The following is a description of a gene set: from publication Yevshin I, Sharipov R, Kolmykov S, Kondrakhin Y, Kolpakov F (PMID 30445619) species: Mus musculus Genes containing one or more binding sites for (Twist1) in their promoter regions (TSS -1000,+100 bp) as identified by GTRD version 20.06 ChIP-seq harmonization. Mouse Gene Set: TWIST1_TARGET_GENES, and this is the list of marker genes: Mir144, Trim37, Map2k1, Tirap, Spi1, Nudt22 (nudix hydrolase 22), Tubg2, Mecom, Sh2d6, Cep131, St6galnac2, Chd1l, Duxf1, Mir5615-2, Spata31e2, Ctsa, Bag2, mt-Ta, Hmgxb3, Prpf4, mt-Tl2, Gm20788, 4930426I24Rik, Bricd5, mt-Tn, Mir6991, mt-Nd1, Slc11a1, Vsig10l, mt-Th, Car5a, E130018O15Rik, Neurl2, Rpp40, Tmem267, Ldlrap1, mt-Te, Fa2h, Ppp1r15b, mt-Ts2, Gm26122, Gem, 9930012K11Rik, Slc22a15, Dlgap5, Mlxipl, Gm16087, mt-Tp, Bicdl1, Gm3716, Cfb, A530053M12Rik, Icam2, Loxhd1, Mus81, Mtnr1a, Kalrn, Hspa2, Il12a, Zfp667, Dscc1, Gm5989, Stk11ip, Slc24a4 (NCBI Gene Id 353057), 1600014C10Rik, Gm15564, Lclat1, Zfp382, Pxylp1, Gm25805, Podxl2, Etv6, Mir6236, Sp2 (Sp2 transcription factor), Sit1 (NCBI Gene Id 54390), Mir6934, mt-Ty, Foxred1, Prdm11, Fbrsl1, Ovca2, Kmt2d, Dync1li1, Srpra, Ncaph, Cfl1, mt-Nd6, Hmx1, Mical1, mt-Rnr2, Utp18, D7Ertd443e, Gm454, Chst13, Tprn, Cd164, Psmd9, Abhd12, 3110070M22Rik, Tnk1, Atp6v0e, Mir1936, mt-Tc (mitochondrially encoded tRNA cysteine), Gm15912, Mir3059 (NCBI Gene Id 100526516), Tppp, mt-Nd5, Tnrc6c, Fyn, Map3k5, 4930555F03Rik, Ubr4, Pum1, Lrrc61, Gm23517, Mex3a, Sfi1, mt-Tv, mt-Tl1, Tmc6, Lamb3, Rab3b, Gm13883, Gm15742, Trpt1, Mcf2l, Cdip1, Aldoa, B4galt3, Gm8357, mt-Tt